Given this list of marker genes H2BC21, HDAC3 (NCBI Gene Id 8841), H2AC25, BRMS1, PHF21A, H2BC12, MTA2, H4C1, H2BC26, H2BC1, H2AC18, H2BC14, MTA1 (metastasis associated 1), H2AC11, H2BC4, HDAC10, SAP30, NCOR2, H2AC4, H2BC13, CHD3, SAP18 (Sin3A associated protein 18), HDAC2, RBBP4, SAP30L, RCOR1, H2BC17, GATAD2B, GATAD2A, KDM1A, H2AC1, NCOR1, GPS2, H2BC9, SUDS3, H2BC15, ARID4A (AT-rich interaction domain 4A), REST, H2BC18, H3C15, RBBP7, MTA3, H2AC14 (H2A clustered histone 14), MBD3, H2BC11, H3C1, H2AC21, H2BC5, H2AC12, HDAC8, H2AC20, ARID4B, H2AC6, HMG20B, HDAC1, H2BC3, TBL1XR1, TBL1X, CHD4, H2AC7, here is a description of the gene set: Reactome Pathway: HDACs deacetylate histones species: Homo sapiens part of: Chromatin modifying enzymes Lysine deacetylases (KDACs), historically referred to as histone deacetylases (HDACs), are divided into the Rpd3/Hda1 metal-dependent 'classical HDAC family' (de Ruijter et al. 2003, Verdin et al. 2003) and the unrelated sirtuins (Milne & Denu 2008). Phylogenetic analysis divides human KDACs into four classes: Class I includes HDAC1, 2, 3 and 8; Class IIa includes HDAC4, 5, 7 and 9; Class IIb includes HDAC6 and 10; Class III are the sirtuins (SIRT1-7); Class IV has one member, HDAC11. Class III enzymes use an NAD+ cofactor to perform deacetylation (Milne & Denu 2008, Yang & Seto 2008), the others classes use a metal-dependent mechanism to catalyze the hydrolysis of acetyl-L-lysine side chains in histone and non-histone proteins yielding L-lysine and acetate. X-ray crystal structures are available for four human HDACs; these structures have conserved active site residues, suggesting a common catalytic mechanism. They require a single transition metal ion and are typically studied in vitro as Zn2+-containing enzymes, though in vivo HDAC8 exhibits increased activity when substituted with Fe2+. The structurally-related enzyme acetylpolyamine amidohydrolase (APAH) (Leipe & Landsman 1997) exhibits optimal activity with Mn2+, followed closely by Zn2+.<br><br>HDACs are often part of multi-protein transcriptional complexes that are recruited to gene promoters, regulating transcription without direct DNA binding. With the exception of HDAC8, all class I members can be catalytic subunits of multiprotein complexes (Yang & Seto 2008). HDAC1 and HDAC2 interact to form the catalytic core of several multisubunit complexes including Sin3, nucleosome remodeling deacetylase (NuRD) and corepressor of REST (CoREST) complexes (Grozinger & Schreiber 2002). HDAC3 is part of the silencing mediator of retinoic acid and thyroid hormone receptor (SMRT) complex or the homologous nuclear receptor corepressor (NCoR) which are involved in a wide range of processes including metabolism, inflammation, and circadian rhythms. <br><br>Class IIa HDACs (HDAC4, -5, -7, and -9) shuttle between the nucleus and cytoplasm (Yang & Seto 2008, Haberland et al. 2009). The nuclear export of class IIa HDACs requires phosphorylation stimulated by calcium or other stimuli. They appear to have been evolutionarily inactivated as enzymes, having acquired a histidine substitution of the tyrosine residue in the active site of the mammalian deacetylase domain (H976 in humans). Instead they function as transcriptional corepressors for the MEF2 family of transcription factors (Yang & Gregoire 2005).<br><br>Histones are the primary substrate for most HDACs except HDAC6 which is predominantly cytoplasmic and acts on alpha-tublin. HDACs also deacetylate proteins such as p53, E2F1, RelA, YY1, TFIIE, BCL6 and TFIIF.<br><br>Histone deacetylases are targeted by structurally diverse compounds known as HDAC inhibitors (HDIs). These can induce cytodifferentiation, cell cycle arrest and apoptosis of transformed cells. Histone literature typically refers to coordinates of the protein after the initiating methionine has been removed.